The following is a description of a gene set: Opportunistic bacterial infection An infection that is caused by a bacterium that would generally not be able to cause an infection in a host with a normal immune system. Such bacteria take advantage of the opportunity, so to speak, that is provided by a weakened immune system. Human Gene Set: HP_OPPORTUNISTIC_BACTERIAL_INFECTION studied in species Homo sapiens, and this is the list of marker genes: STX1A, DCTN4, CEACAM6, ZNFX1, TGFB1, GSTM3 (NCBI Gene Id 2947), MIF, CFTR, SLC6A14, CLCA4, EDNRA, IKBKG, SLC26A9, SLC11A1, SLC9A3, MPEG1, PDCD1, ZNF341, SERPINA1, CYBB, CEACAM3, IRF1, IGKC, GCLC, KCNN4, HMOX1, IL12RB1, IGHG2, HFE